Given this list of marker genes Macroh2a1, Cct6a, Cct4, Gnl3, Cct8, Acd, Gnl3l, Cct3, Pml, Terf1, Cct5, Dkc1, Wrap53, Cct2, Tcp1, Cct7, here is a description of the gene set: Any process that modulates the frequency, rate or extent of protein localization to chromosome, telomeric region. species: Mus musculus Mouse Gene Set: GOBP_REGULATION_OF_PROTEIN_LOCALIZATION_TO_CHROMOSOME_TELOMERIC_REGION